Given this list of marker genes MEG3, PKDCC, RTL1, GDF5, PTRH2, ERI1, PIK3CD, IHH, KNSTRN, FGFR2, DLK1, here is a description of the gene set: Displacement of the 3rd finger from its normal position. Human Gene Set: HP_DEVIATION_OF_THE_3RD_FINGER studied in species Homo sapiens Deviation of the 3rd finger